The following is a description of a gene set: Any functional anomaly of the tongue. Human Gene Set: HP_ABNORMAL_TONGUE_PHYSIOLOGY Abnormal tongue physiology studied in species Homo sapiens, and this is the list of marker genes: OPTN, SLC25A21, MPZ, SCN9A, TBCD, VCP, ATP1A2, MTPAP, AGTPBP1, RMND1, EXOSC8, ELP1, ANXA11, FIG4, AIFM1, UBQLN2, FRAS1, RILPL1, DAO, ANG, TRANK1, CACNA1A, ATP13A2, GAA, EGR2, PPARGC1A, SMN1, SYT2, GLT8D1, PRX, CFAP410, PFN1, KIF1A, LRP12, TARDBP, NOP56, PRUNE1, SOD1, ATP11A, SMN2, PRRT2, TREM2, NEFH, FXR1, SLC52A3, SLC25A46, NDUFS4, PON1, CCNF, ATXN2, TAF15, VAPB, DCTN1, UNC13A, SBF2, PON2, TUBB4A, PLCB4, ALS2, RETREG1, SH3TC2, PON3 (NCBI Gene Id 94886), NOTCH2NLC, MATR3, ASAH1, PRPH, TBK1, SLC39A4, MEGF10, GNAI3, WNK1, TOE1, KCNK9, NTRK1, UBA1, SQSTM1, NEK1, FUS, TSPYL1, EXOSC9, ADPRS, PMP22, CHCHD10 (NCBI Gene Id 400916), GLE1, SCN1A, EDN1, SLC52A2 (solute carrier family 52 member 2), ERBB4, POLG, GIPC1, SYNGAP1, SPTLC1, LGI3, VWA1, VRK1, CHMP2B, HNRNPA1, EXOSC3